The following is a description of a gene set: Mouse Gene Set: GOBP_CAMP_BIOSYNTHETIC_PROCESS The chemical reactions and pathways resulting in the formation of the nucleotide cAMP (cyclic AMP, adenosine 3',5'-cyclophosphate). studied in species Mus musculus, and this is the list of marker genes: Pth2, Adcy5, Adcy10, Adcy6, Adcy8, Adcy3, Adcy2, Adcy4, Adcy9, Adcy1, Adcy7